The following is a description of a gene set: studied in species Homo sapiens Human Gene Set: GOMF_TRANSPORTER_INHIBITOR_ACTIVITY Binds to and stops, prevents, or reduces the activity of a transporter., and this is the list of marker genes: OXSR1, CALM2, SLC30A1, MICU1, HAMP, TNNI3, NHERF4, CAV3, NEDD4, STK39, ANKRD36C, WWP2, STX8, YWHAE, MCUB, VAMP8, SCN3B, CFTR, RACK1, WNK4, PACSIN3, KCNV1, PLN, AMBP, CALM1, LAMP2, KCNK2, CAV1, FKBP1B, NEDD4L, RSC1A1, ENSA, STOM, ITPR1, LYNX1, STX1A (syntaxin 1A), KCNE4, PCSK9, KCNMB2, LAMP1, PHPT1, CALM3, SCN1B, TMC7, VTI1B (vesicle transport through interaction with t-SNAREs 1B), RASA1, BCL2, CAMK2D, COMMD1, ANO9, GSTM2, STX7